Given this list of marker genes GSC, LMX1B, COL5A2, COL5A1, IFITM5, COL1A1, BMP1, ATR (NCBI Gene Id 57307), DONSON, KIF22, ERCC1, B3GAT3, FGFR2, ROR2, CYP26B1, CD96, AFF3, ERI1, FZD2, WNT7A, B3GALT6, FGF9, TBX15, NIPBL, ARID1B, SOX9, WNT5A, CHST3, ASXL1, PTDSS1, SCARF2, NOTCH2, EXTL3, POR, COL27A1 (collagen type XXVII alpha 1 chain), SLC39A13, L1CAM, EXOC6B, EP300, FGFR1, GDF5, GPC6 (glypican 6), NOG (noggin), FLNA (NCBI Gene Id 8272), SHOX (SHOX homeobox), PRKAR1A, SKI, CREBBP, CLCN3 (chloride voltage-gated channel 3), DVL1 (dishevelled segment polarity protein 1), CHRNG, RNU4ATAC, SRCAP, MAP3K7, B4GALT7, CDC45, here is a description of the gene set: Human Gene Set: HP_ABNORMALITY_OF_THE_HUMERORADIAL_JOINT studied in species Homo sapiens Abnormality of the humeroradial joint